The following is a description of a gene set: The process, occurring during the embryonic phase, whose specific outcome is the progression of the skeletal joints over time, from formation to mature structure. species: Homo sapiens Human Gene Set: GOBP_EMBRYONIC_SKELETAL_JOINT_DEVELOPMENT, and this is the list of marker genes: HOXC11, HYAL1, BMP7, BMP4, IHH, HOXA11, SLC2A10, HOXD11, NOG, CTNNB1, COL2A1, WNT9A, OSR1, OSR2, EXT1, SHOX2 (NCBI Gene Id 6474)